Given this list of marker genes ITSN1, GHRL, SERP1, GHRHR, DRD2, SELENOT, GHRH, GABBR1, ADCYAP1, here is a description of the gene set: species: Homo sapiens Any process that increases the frequency, rate or extent of the regulated release of growth hormone from a cell. Human Gene Set: GOBP_POSITIVE_REGULATION_OF_GROWTH_HORMONE_SECRETION